The following is a description of a gene set: Limitation of knee mobility species: Homo sapiens Human Gene Set: HP_LIMITATION_OF_KNEE_MOBILITY An abnormal limitation of knee joint mobility., and this is the list of marker genes: FLNC, GPC6, GABRA1, EXT1, FLNA, COL9A3, SCN9A, GABRG2, ASAH1, PCDH19, CSGALNACT1, DYM (dymeclin), SCN1B, COL2A1, ECEL1, HGD, STX1B, SCN2A, FBN2, EXT2, VCP, TOR1A, MYOT (NCBI Gene Id 9499), FILIP1, DYSF, EZH2 (enhancer of zeste 2 polycomb repressive complex 2 subunit), FGF13, ATP7A, DPYSL5, PRRT2, ADGRV1, BMP1, MAP3K7, SCN1A (sodium voltage-gated channel alpha subunit 1), HCN1, GABRD